Given this list of marker genes Atp2b2, Mlst8, Ulk3, Acss2, Rnf146, Mmp2, Slc26a1, Nat8l, Prdm16, Maml1, Gspt1, Grip2, Pbx1, Slc5a7, Bmp7, Ppp2r5b, Cnp, Pcdhb15, Fut10, Tmem86a, Map3k12, Tulp3, Brwd3, Pacsin1, Cybrd1, Pou6f1, Gabarap, Apba1, Traf3 (NCBI Gene Id 22031), Nfyc, Dcaf7, Tpm3, Serpina3m, Stac2, Tspan9, Il12rb2, Iqck, Slc8a3, Spred3, Dnajb11, Trpc4ap, Sidt2, Gpx3, Dhrs4, Igdcc3, Camk1d (calcium/calmodulin-dependent protein kinase ID), Ube2r2, Slc24a3, Atp6v0a1, Lmo1, Scn2b, Cdk14, Cdk5r2, Foxc2, Znrf3, Shisal1, Itga4, Pou2f1, Kmt2a, Spout1, D2hgdh, Coro2b, Myo18a (myosin XVIIIA), Pcm1, Nfic, Carnmt1, Ly6e, Mfrp, Septin2, Braf, Tnfaip2, Pim2, Bahcc1, Phb1, Mfn2, Tgfbrap1, Abhd12, Lypd6b, Zfp512b, Rac2, Hook1, Slc48a1, Serpina3c, Dlg2, Fhip2b, Prr14l, Zfp593, Zdhhc3, Slco2a1, Tnrc6b, Gatad2b, Oas1g, Ttll11, Wfikkn2, Lmbrd1, Ttyh3, Col1a1, Ankrd63, Ar, Ppp1r12a, Naa60, Bard1, Arhgef25, Zfhx2, Adam11, Celf5, Cryba1, Msrb3, Ly6c1, Rtl8c, Clmn, Dbndd1, Fam120c, Elfn2, Oas1a, Rps6ka2, Slc6a17, Cpeb2 (NCBI Gene Id 277866), Chst15 (NCBI Gene Id 77590), St3gal4, Kprp, Numbl, Krt80, Rcn1, Cimap3, Cplx1, Rab3b, Epha8, Pex19, Tcf7l1 (NCBI Gene Id 21415), Ikzf4, Scn4b, Grm1, Parva, Slc23a2, B3gntl1, Mslnl (NCBI Gene Id 328783), Ncam2, Max, Nek6, Atp2b4, Crtc3, Gnb3, Zer1, Usp6nl, Adar, Ccng1, Gsta4, Ubald2, Srpra, Zgpat, Cyth1, Nrxn2, Arnt2, here is a description of the gene set: species: Mus musculus Genes predicted to be targets of miRBase v22 microRNA mmu_miR_5107_5p in miRDB v6.0 with MirTarget v4 prediction scores > 80 (high confidence targets). from publication Chen Y, Wang X (PMID 31504780) Mouse Gene Set: MIR_5107_5P